The following is a description of a gene set: from publication Feuerer M, Hill JA, Kretschmer K, von Boehmer H, Mathis D, Benoist C (PMID 20231436) Human Gene Set: GSE20366_EX_VIVO_VS_DEC205_CONVERSION_NAIVE_CD4_TCELL_UP Regulatory T (Treg) cells that express the FoxP3 transcription factor are essential for lymphoid homeostasis and immune tolerance to self. Other non-immunological functions of Treg cells, such as controlling metabolic function in adipose tissue, are also emerging. Treg cells originate primarily in the thymus, but can also be elicited from conventional T cells by in vivo exposure to low-dose antigen or homeostatic expansion, or by activation in the presence of TGFβ in vitro. Treg cells are characterized by a distinct transcriptional signature controlled in part, but not solely, by FoxP3. For a better perspective on transcriptional control in Treg cells, we compared gene expression profiles of a broad panel of Treg cells from various origins or anatomical locations. Treg cells generated by different means form different sub-phenotypes identifiable by particular combinations of transcripts, none of which fully encompass the entire Treg signature. Molecules involved in Treg effector function, chemokine receptors, and the transcription factors that control them are differentially represented in these subphenotypes. Treg cells from the gut proved dissimilar to cells elicited by exposure to TGFβ, but instead they resembled a CD103+Klrg1+ subphenotype preferentially generated in response to lymphopenia. Genes up-regulated in comparison of TconvLP versus DEC-Pept CD25- (see Table S1 in the paper for details). studied in species Homo sapiens, and this is the list of marker genes: CLSPN, CYSLTR2, IDUA, SRBD1, FAM20A, EPS8L1, FIGNL1, RYR1, BUB1, WRN, RREB1, MTNAP1, CDK1, FKBP5, AFP, B3GALT5, EXO5, CORO2A, CD160, TENT5A, UNC5CL, PRC1, EPAS1, AP3M1, GNGT2, RAD51AP1 (NCBI Gene Id 10635), TTC21B, GOLPH3L, DNAJC16, PHETA2, IFIT1, DNAAF9, TMEM154, RSAD1, CHSY1, SERPINB1, FGL2, RNF5, CYP1B1, OTUD7B (OTU deubiquitinase 7B), OSBPL3, SOAT2 (sterol O-acyltransferase 2), PLAC8, ABI3, ENSG00000286190, CEPT1, KLHDC1, HIGD1C, NAV2, SREK1IP1, LDLR, IL17A, CNGA1, MATN2, D2HGDH, NDC80, DNA2, CENPH, CARD10, WDR12, CCL5, TEX2, MITD1, XKRX, RIOX2, EID3, IGFBP4, RNF34, TRIM56, SLAMF7, TMEM176A, CCR1, PDE3B, STAP1, GPR65, TBCCD1, ASAH1, LINC00511, CCR6, JPT2, N4BP2L1, TMT1A, OVCA2, NUF2, LITAF, FAM111A, SRGAP3, INPP1, MORC1, RMDN2, RAD50, ACP3, NSG2, IL12RB1, PPM1K, MNS1, ANLN, HIP1, RPS9, TMEM176B, HSPA1A, FAM241A, GPR34, NSD2, PLIN2, SIK1, TTPAL, IL17RE, ABCB1, SDF2, HOPX, GZMA, NCAPG2, NCOA7, TNIK, ZBTB24, CHST11, IL1R1, CCR2, MOSMO, KIAA0232, LY6E (NCBI Gene Id 7999), MVD, B4GALNT2, IL22, KLHL20, ZBTB26, LYSMD2, IL12RB2, AMPD1, C2orf49, ADAM19, GEMIN6, IL18RAP, GZMK, JDP2, ALDH7A1, KNTC1, SLC16A6, MGAT4A, SNX25, RNF135, FRYL, CCR5 (C-C motif chemokine receptor 5), TRIM32, ABHD15, CDK6, HLF, UBXN7, CIPC, ACTN2, FRA10AC1 (NCBI Gene Id 57208, FRA10A associated CGG repeat 1), TRAF3IP1, H2AB2, IVD, CCND2, PLEKHF1, KCTD9, CYP2D6, BIK, ANKRD6, LZTFL1, ADGRG5, BAIAP3, ELP4, RASGRP1 (RAS guanyl releasing protein 1), GZMB, TEC, RCBTB2, RNF130, ASB2, B4GALNT4, GBP2, HDAC8, IL17RB, RGS1, NUSAP1, EXOC2, RNASE4, LETMD1, PRDM1, HIC1, AHRR, ZNF7, STAT1, APPL2, XCL1, TADA2A, SYTL3, CENPN, SLC15A2, FFAR2, NUP37, CERK, TTC39C, MTIF2, THBD, RCN1, P2RX7, DNM1L